Given this list of marker genes PDK1, BCKDK, PDK3, PDK4, PDK2, here is a description of the gene set: species: Homo sapiens Human Gene Set: GOMF_PYRUVATE_DEHYDROGENASE_ACETYL_TRANSFERRING_KINASE_ACTIVITY Catalysis of the reaction: ATP + L-seryl- = ADP + H+ + O-phospho-L-seryl-.